The following is a description of a gene set: p75NTR regulates axonogenesis species: Mus musculus Mouse Gene Set: REACTOME_P75NTR_REGULATES_AXONOGENESIS, and this is the list of marker genes: Ngfr, Rtn4, Mcf2, Ngf, Rhoa, Arhgdia (Rho GDP dissociation inhibitor alpha), Lingo1, Omg, Mag